The following is a description of a gene set: Catalysis of an oxidation-reduction (redox) reaction in which NADH or NADPH acts as a hydrogen or electron donor and reduces an oxygen molecule. Human Gene Set: GOMF_OXIDOREDUCTASE_ACTIVITY_ACTING_ON_NAD_P_H_OXYGEN_AS_ACCEPTOR studied in species Homo sapiens, and this is the list of marker genes: NCF1C, FMO5, CYBB, NOS3, NCF1B, SH3PXD2B, PDGFB, NCF2, NOXA1, MICAL2, NOXO1, DUOX2, DUOX1, NOX1, AGT, MICAL1, CYB5R4, CYBA, AIFM1, KMO (kynurenine 3-monooxygenase), PYROXD1, NOX3, NOX5, NOX4, NCF1, SH3PXD2A, NCF4